The following is a description of a gene set: Enables the transmembrane transfer of a solute by a channel that opens in response to a specific stimulus. studied in species Homo sapiens Human Gene Set: GOMF_GATED_CHANNEL_ACTIVITY, and this is the list of marker genes: HTR3D, CLCN6, KCNJ15, GRIN3A, KCND2, GPR89B, GABRB3, KCNJ18, TMEM37, KCNIP2, GRIA2, CHRNG, KCNQ1, GRIN2B, KCNH3, TMEM266, KCNG2, SCNN1D, KCNJ14, P2RX6, CLCA2, ANO5, MCOLN2, P2RX2, GABRR1, LRRC52, ANO6, CACNG1, KCNJ6, TMEM63B, CLCA1, HCN1, CACNG3, KCNQ5, KCNJ2, GRIN3B (glutamate ionotropic receptor NMDA type subunit 3B), CHRNA1, KCNE2, NALF1, CACNA1S, KCNJ8, CNGA4, MCOLN3, KCNJ13, TTYH3, GABRR3, SNAP25, KCNB1, CACNA1C, GRIK1, CACNA1D, ITPR3, TRPC3 (NCBI Gene Id 7222), KCNH8, KCNJ10, KCNK4, AQP1, HCN3, KCNJ5, CACNG4 (calcium voltage-gated channel auxiliary subunit gamma 4), ABCC8, CHRNA9, TRPM8, TMC1, CACNA1G, GABRR2, TPCN2, ANO10, KCNC4, KCNK6, KCNN3, KCNK2, KCNK12, CHRNA6, KCNK15, GPR89A, CATSPER2, HCN2, KCNH5, KCNE5, KCNJ16, SLC1A5, CLCNKB, KCNJ1, CLCN1, CACNA1E, CLCN2, CALHM6, TTYH2, NMUR2, CCT8L2, ASIC5, SHROOM2, CNGA1, PKD2, KCNAB2, SCNN1A, TMC4 (transmembrane channel like 4), CHRNA3, CLCN5, GRIA3 (glutamate ionotropic receptor AMPA type subunit 3), PKD1L3, P2RX3, CHRNA10, CACNG2, KCNE3, TMEM150C, KCNJ4 (NCBI Gene Id 3761), CACNA2D2, ITPR2, GABRQ, CACNG7 (calcium voltage-gated channel auxiliary subunit gamma 7), VDAC2, BEST1, KCNE1, GRIN2C, KCNJ11, GRIK5, CNGB3, KCNF1, GABRA2, PIEZO1 (piezo type mechanosensitive ion channel component 1 (Er blood group)), TRPV4, ANXA6, RYR3, KCNAB3, CACNG5, KCNN4, GABRA1, ANO1 (NCBI Gene Id 55107), KCNA10 (potassium voltage-gated channel subfamily A member 10), TTYH1 (NCBI Gene Id 57348), KCNB2, PIEZO2, P2RX5, LRRC55, CHRNB2, KCNQ3, KCNN2, CACNG8, CNGA2 (cyclic nucleotide gated channel subunit alpha 2), SCNN1B, KCNK3, KCNG3, GABRG2, CACNB2, GABRP, GRIK4, GABRB2, HTR3A, KCND3, CACNA2D4, GABRA6, KCNA7, CHRNA7, KCNA1, CHRNB3, KCNC1 (NCBI Gene Id 3746), KCNA6, MCOLN1, KCNG4, KCNA5, BEST2, KCND1, ITGAV, TSPOAP1, NCS1 (NCBI Gene Id 23413), KCNK16, ANO8, HCN4, TMEM63A (transmembrane protein 63A), GABRG1, GRID1, CATSPER1, TRPM4 (transient receptor potential cation channel subfamily M member 4), KCNJ3, CALHM1, CACNB1, TRPA1, HVCN1, CHRNB4, CHRNB1, CACNA1B, GRIK2, TMC7, ANO7, TMC5, KCNQ2, PACC1, SCN10A, KCNG1, CNGA3, NALF2, KCNA2, ASIC3, KCNH1, KCNN1, KCNMB1, CACNA1H, CALHM3, LRRC38, GLRA2, TRPM2, KCNAB1, GABRA5, TMEM63C, SCN1A, CAV1, CLCN4, SLC1A7, GRIN1, OPRM1, CLCNKA, KCNK1, ANO2, CATSPER3 (cation channel sperm associated 3), GLRA1, KCNS1, RYR1, GABRG3, KCNS2, VDAC1, CNGB1, CACNA2D3, HTR3C (5-hydroxytryptamine receptor 3C), KCNH6, BNIP1 (BCL2 interacting protein 1), CCDC51, CACNA1I, KCNA4, KCNH4, BEST3, GLRB, P2RX7, GLRA3, HTR3B, ASIC1, P2RX1, KCNT2, KCNQ4, ZACN, TMC6, KCNV2, KCNK5, SCNN1G, CACNB3, TMC2, GABRD, KCNJ9, RYR2, CHRFAM7A, GRIN2D, KCNT1, ANO4, LRRC26, ABCC9, CACNA2D1, SCN7A, P2RX4, AQP6, KCNK17, KCNE4, TMC8 (transmembrane channel like 8), TRPV1, TMEM87A, KCNK7, KCNK18, KCNS3, CHRNA4, KCNMB4, CHRNE, CATSPER4, CACNA1F, CHRNA2, CYBB, TPCN1, VDAC3, SLC17A3, KCNV1, KCNH2, TRPM5, CHRND, GABRE, GRIK3, KCNJ12, KCNH7, GRIN2A, SLC17A7, CLCN3, ASIC2, ANO9, KCNA3, SCN2B, PKD2L1, KCNK10, GABRA4, TMEM109, CACNB4, KCNK9, KCNMB2, KCNK13, KCNC3, KCNU1, KCNMB3, BEST4, GRIA1, GRIA4, KCNMA1, HTR3E, CACHD1, CHRNA5 (NCBI Gene Id 1138), CFTR, CLCA4, ITPR1, TMC3 (NCBI Gene Id 342125), GABRB1, ANO3, ASIC4, GABRA3, GRID2, CACNG6, KCNC2, CACNA1A